Given this list of marker genes SHOX, ESCO2 (establishment of sister chromatid cohesion N-acetyltransferase 2), FLNA, EIF4A3, ROR2, here is a description of the gene set: Shortening of the middle parts of the arm in relation to the upper and terminal segments. studied in species Homo sapiens Mesomelic arm shortening Human Gene Set: HP_MESOMELIC_ARM_SHORTENING